The following is a description of a gene set: studied in species Homo sapiens Lymphedema Human Gene Set: HP_LYMPHEDEMA Localized fluid retention and tissue swelling caused by a compromised lymphatic system., and this is the list of marker genes: ADAMTS3, THSD1, TIE1, RELN, NRAS, VEGFC, HLA-DRB1, ANGPT2, NAGA, LZTR1, CBL, FZD4, PTPN11, RRAS, LRP5, CDC42, NAA10, TSC1, AKT1, DNMT1, RIT1, BCL2, MRAS, SHANK3, PIK3CA, INPPL1, GJC2, RASA2, ANTXR2, RASA1, EPHB4, TSC2, RRAS2, CTNNB1, ZNF408, CELSR1, PTPN14, XYLT2, RAF1, KIF7, CDK5, PTEN, BCL6, FAT4, KRAS, SOX18, NDP, CCBE1, PIEZO1, FLT4, MAPK1, SLC35D1, ABCC9, GUSB, TSPAN12, SPG11, MDFIC, HRAS (NCBI Gene Id 338029), SOS1, MAP2K2, SPRED2, LBR, BRAF, KIF11, GATA2, MAP2K1, DCHS1, ERG, IKBKG, ACVR1, GLA, FOXC2, SOS2, NLRP3, PMM2